The following is a description of a gene set: studied in species Homo sapiens Human Gene Set: GOBP_RESPONSE_TO_INTERLEUKIN_18 Any process that results in a change in state or activity of a cell or an organism (in terms of movement, secretion, enzyme production, gene expression, etc.) as a result of an interleukin-18 stimulus., and this is the list of marker genes: PDGFB, IL18R1, IL18RAP, CYLD, TICAM2, RIPK2, AKT1, IL18, PIK3R1, NLRP6, CASP4, CLDN1